The following is a description of a gene set: species: Homo sapiens Cystoid macular edema Cystoid macular edema (CME) is any type of macular edema that involves cyst formation. Human Gene Set: HP_CYSTOID_MACULAR_EDEMA, and this is the list of marker genes: IMPG2 (NCBI Gene Id 51443), TUB, NRL, RDH12, SPATA7, HGSNAT, PRCD, DHDDS, CLRN1, CNGA1, RHO, IFT172, USH2A, PRPF31, RBP3, ABCA4, IDH3B (isocitrate dehydrogenase (NAD(+)) 3 non-catalytic subunit beta), TOPORS, PDE6A, IMPDH1, PCARE, IMPG1, SAG, CA4, TTC8, RPGRIP1, KIZ, ROM1, ZNF408, RP1L1, ARHGEF18 (NCBI Gene Id 85008), AHR, CC2D2A, ARL6, BEST1, RDH5, HLA-A, RPE65, BBS2, RP1, MERTK, RP9, FSCN2, CRX, LRAT, IFT140, SLC7A14, GUCA1B, NEK2, ZNF513, SCAPER, DHX38, EYS, RLBP1, FAM161A, NR2E3, MFRP, AGBL5, NOD2, PDE6B, RPGR, OFD1, ARL2BP, RP2, CFAP418, PRPF8, CYP4V2, CERKL, CDHR1, IFT88, SNRNP200, PRPH2, PRPF4, ARL3, REEP6, KIAA1549, PRPF3, SEMA4A, AHI1, IDH3A, CNGB1, TULP1, MAK, PRPF6, RGR, BBS1, CRB1, PDE6G, PROM1, KLHL7, POMGNT1